Given this list of marker genes RPN2, RPN1, DDOST, ALG8 (ALG8 alpha-1,3-glucosyltransferase), ALG6, ALG10, STT3A (NCBI Gene Id 8071), DAD1, ALG10B, STT3B (NCBI Gene Id 201595), TUSC3, here is a description of the gene set: Pathway Definition from KEGG: G00007+Glc-P-Dol -- ALG6 >> ALG8 >> ALG10 >> (STT+OST) -> G00009 N-Glycan precursor biosynthesis, ALG6 to OST. Pathway ID: N00681. Pathway type: Reference. Pathway class: nt06015 N-Glycan biosynthesis. Human Gene Set: KEGG_MEDICUS_REFERENCE_N_GLYCAN_PRECURSOR_BIOSYNTHESIS_ALG6_TO_OST studied in species Homo sapiens